The following is a description of a gene set: Genes down-regulated in lung relapse of breast cancer. We explored whether the five previously reported molecular subtypes in breast cancer show a preference for organ-specific relapse and searched for molecular pathways involved. The intrinsic gene list describing the subtypes was used to classify 344 primary breast tumors of lymph node-negative patients. Fisher exact tests were used to determine the association between a tumor subtype and a particular site of distant relapse in these patients who only received local treatment. Modulated genes and pathways were identified in the various groups using Significance Analysis of Microarrays and Global Testing. Bone relapse patients were most abundant in the luminal subtypes but were found less than expected in the basal subtype. The reverse was true for lung and brain relapse patients with the remark that absence of lung relapse was luminal A specific. Finally, a pleura relapse, although rare, was found almost exclusively in both luminal subtypes. Many differentially expressed genes were identified, of which several were in common in a subtype and the site to which the subtype preferentially relapsed. WNT signaling was up-regulated in the basal subtype and in brain-specific relapse, and down-modulated in the luminal B subtype and in bone-specific relapse. Focal adhesion was found up-regulated in the luminal A subtype but down-regulated in lung relapse. The five major molecular subtypes in breast cancer are evidently different with regard to their ability to metastasize to distant organ(s), and share biological features and pathways with their preferred distant metastatic site. Human Gene Set: SMID_BREAST_CANCER_RELAPSE_IN_LUNG_DN species: Homo sapiens from publication Smid M, Wang Y, Zhang Y, Sieuwerts AM, Yu J, Klijn JG, Foekens JA, Martens JW (PMID 18451135), and this is the list of marker genes: DUSP6, ADH1B, CXCL14, ASPN, SCGB2A2, SCGB1D2, CLDN5, HMGCS2, CILP, TTC12, ADIPOQ, LRRN3, TIMP4, FABP4, RAPGEF3, SFRP4, TNXA, PPP1R1A, DPT (dermatopontin), DNALI1, TOX3, SCGB2A1, SLC1A1, LMOD1, LRRC31, PDCD4, COL14A1, TFF1, TBC1D19, ACKR1, SCUBE2, ITGA7, PRODH, TFAP2B, ABCA8, IGF1, COMP, NAT1